The following is a description of a gene set: Genes predicted to be targets of miRBase v22 microRNA hsa-miR-4428 in miRDB v6.0 with MirTarget v4 prediction scores > 80 (high confidence targets). species: Homo sapiens Human Gene Set: MIR4428 from publication Chen Y, Wang X (PMID 31504780), and this is the list of marker genes: MS4A2, CCNY, ZNF275, SHFL, FAM78B, ARPP19, SLC17A8, KRR1 (KRR1 small subunit processome component homolog), TPCN2, NUFIP2, PDGFC, MIB1, OR51E2, SOSTDC1, CHD4, DNAJC24, SLC66A1LP, UBE2Q1, BTN2A2, EPM2AIP1, COX7A2L, ST8SIA6, TMEM273, GPX6, SPRY3, KLHDC7A, CEP41, ATP8B2, PFN2, C2orf49, MATCAP2, RNF217, DCAF12, RAB11FIP2, MSH4, CCDC34, ACLY, SF1, KLHL13, DCAF7, PBX1 (NCBI Gene Id 5087), PARP9, LIX1L, SON, CCT8, HEMGN, CLCA2, ZCCHC2, DLGAP1, ESRRG (NCBI Gene Id 2104), BCDIN3D, DLG1, KLF9, STK39, NEB, CDCA8, ZNF644, ENTPD1, HIVEP3, SYTL5, GTF2E1, EGR3, ASTN2, PNPLA4, GLP2R, RNF157, YIPF6, ARMS2, SLC7A7, DGKK (NCBI Gene Id 139189), KLHL9, SYNGAP1, ADAR, KAT6A, CCDC88A, C6orf62, INO80D (INO80 complex subunit D), MECP2, ABRAXAS1, HERC3, EPHB1, ZBTB41, PPFIA2, NCBP1, FAM98A, ATP6AP1, PAK2, TMEM80, XYLT1, AP3D1, TCF7L2, IGDCC4, TBC1D5, PRRC2B, LCE2D, TMEM33, ZFP91, ABCB5, ZNF84, ANKRD52, CKMT2, GNB3, SUPT7L, CEP170, LAMA4, RELN, RHOG, FUBP3, THAP9, SUPT16H, TPM3, MAP2K4, CADM2, SH3TC2, SCN1A, ZSCAN16, CD1C, CHCHD3, BCL9, AAK1 (NCBI Gene Id 652453), KLF7, FBXW11, PTGES3, BRK1, MESP2, PIGN (phosphatidylinositol glycan anchor biosynthesis class N), GABRA6 (gamma-aminobutyric acid type A receptor subunit alpha6), MSI2, LCE1E, MED28